The following is a description of a gene set: studied in species Homo sapiens Any process that modulates the frequency, rate or extent of protein catabolic process in the vacuole. Human Gene Set: GOBP_REGULATION_OF_PROTEIN_CATABOLIC_PROCESS_IN_THE_VACUOLE, and this is the list of marker genes: LRP2, CD81, ATP13A2, VPS35, GGA3 (golgi associated, gamma adaptin ear containing, ARF binding protein 3), USP8, MARCHF2, MFSD8, MGAT3, RNF128, LDLR, LRP1, LAPTM4B, GBA1